Given this list of marker genes EPHB2, ARHGAP35, DAB2IP, DLC1, RASA4, SCAI, CGNL1, MAPKAP1, SLIT2, ITGB1, NUP62, CD2AP, TRIM67, RASIP1, RASA3, MIR29B1, ARHGAP12, KANK1, FBP1, KCTD10 (potassium channel tetramerization domain containing 10), STMN1, ITGA3, CYRIB, ARHGAP42, SH3BP1, RASA4B, CCDC125, ABL2, SPRY4, RASAL1, HEG1 (heart development protein with EGF like domains 1), ARHGAP24, LZTR1, KCTD13, STAMBP, RIPOR2, GIT1, ARHGAP45, RASA2, WNK1, TGFB2, ARHGAP30, RABGEF1, SYNGAP1, RIPOR1, STMN3, ARHGAP29, MET, CUL3, SPRY3, GMIP, SPRY1, ARHGAP44, ARHGAP25, SPRY2, FLCN, PPP2CB, RASAL3, BCL6, MIR223, NF1, TNFAIP1, MIR21, MYOC, ARHGAP17, MFN2, ARHGAP22, here is a description of the gene set: Any process that stops, prevents, or reduces the frequency, rate or extent of small GTPase mediated signal transduction. studied in species Homo sapiens Human Gene Set: GOBP_NEGATIVE_REGULATION_OF_SMALL_GTPASE_MEDIATED_SIGNAL_TRANSDUCTION